Given this list of marker genes Garre1, Ugt1a10, Sh3bp5l (SH3 binding domain protein 5 like), Tceal3, Rab5c, Mob3c, Sox8, Ugt1a1, Tmem154, Ddo, Ldlrap1, Spock1, Utp25, Zbtb14, Errfi1, Ugt1a9 (UDP glucuronosyltransferase 1 family, polypeptide A9), Kirrel1, Cytip, Ugt1a7c, Zfp46, Kdm5c, Gpcpd1, Ugt1a6a, Fgfr1, Pi4k2b, Ehd2 (NCBI Gene Id 259300), Ugt1a5, Prkacb, Azi2, C1ql1, Spata1, Cnot2, Vim, Ptbp3, Tcf24, Krt32, Arnt, Ctdspl, Dnm2, Ugt1a2, Rtl5, Pcyt1b, Ppp2r3d, Oxtr, 4930544G11Rik, E2f2, F8a, Ctdspl2, Ttn, Gpr3, Foxn3, Tmem245, Arhgef17, Cdk8, Tceal6, C87436, Slc25a5, Cers3, Hdlbp, Usp19, Crim1, Slc7a11 (NCBI Gene Id 99638), Vmp1, Gtpbp10, Slit2 (NCBI Gene Id 338531), Sult1d1, Tmod2, Nsd3, Smndc1, Bmal2, Ell2, Stmnd1, Qki, here is a description of the gene set: from publication Chen Y, Wang X (PMID 31504780) Mouse Gene Set: MIR_540_3P studied in species Mus musculus Genes predicted to be targets of miRBase v22 microRNA mmu_miR_540_3p in miRDB v6.0 with MirTarget v4 prediction scores > 80 (high confidence targets).